The following is a description of a gene set: species: Homo sapiens Platybasia Human Gene Set: HP_PLATYBASIA A developmental malformation of the occipital bone and upper end of the cervical spine, in which the latter appears to have pushed the floor of the occipital bone upward such that there is an abnormal flattening of the skull base., and this is the list of marker genes: SH2B1, GP1BB, NOTCH2, SIK3, COL1A1, RREB1, LBR, UFD1, COMT, HIRA, FLNB (filamin B), COL1A2 (NCBI Gene Id 1278), ARVCF, NOTCH3, JMJD1C, TBX1, SEC24C